Given this list of marker genes SSTR1, SOD3 (NCBI Gene Id 6649), GDPD3, PMEL, KIR2DL1, THBD, PCBP3, ZNF711 (zinc finger protein 711), MROH7, TESMIN, CKAP5, RNF186, CDK14, ATRNL1 (NCBI Gene Id 26033), GUCY1A1, CPT1A, SYNGR4, TAS2R14, BCL2L14, CPPED1, SMG7-AS1, KIR2DS4, ARHGEF3, POMZP3, MYOZ2, FOXD1, FCHSD2 (NCBI Gene Id 9873), CPS1, ART3, FLJ13224, KCNQ3, PWAR5, PRLR, HTR1D, PLG, RHBG, FST, HIF3A, RPL23AP53, TEC, KCNK15-AS1, SPO11, SERPINF1, KIR3DL1, PPFIA2, ADCY3, FAM204A, NEUROD6, HOXD1, VDR, FER1L4, GCNT3, DAB2, AMT, LINC00588, DNAJC12, RUBCNL, REN, PDZD2, AEN, SLC25A20, PDLIM7, TNFSF11, GRAMD1C, ZNF507, NKRF, UNC13B, VIPR2 (NCBI Gene Id 94613), ALDH4A1, MPDU1, LDB3, PCDHA2, MAMLD1, PLPP3, KCNJ14, IQSEC3, FAM131B, NPBWR2, XYLB, UCP1, GDF5, BEST2, KRT33B, SOBP, CNGB1, DRP2, PAFAH2, IL1RN, MYLK, PLD1, SLC39A2, TDO2, CD163, CHRM5 (NCBI Gene Id 1133), SIX6, CTTN, SLC2A9, CST5, ANXA2P3, SEMA5A, GPR88, MAGI2, IGFBP3, EXOSC1, SH3GL2, HABP2, KRT19P2, UBE2G2, PKD2L2, CLCN5, MSH4, TBX6, PRR3, ATP6V0A1, MZB1 (marginal zone B and B1 cell specific protein), HBQ1, TRPC6, IL1R2, FXYD3, DNAJC22, C5AR2, TMPRSS5, CUZD1, EGOT, RAMP3, REEP1, LY6G6C, EXTL2, VWF, B4GALT2, ZCWPW1, IL13RA1, GRIK3, BLNK, KSR1, RABEP2, SYT2, AADAC, NRG1, GYS2, KCNJ10, HLCS, RFPL3, FSCN3, DLGAP2, SPACA1, DGCR5, ITGB5, SATB2, GREM2, TUBA8, LEPR, MAGEA12, CLCC1, PEAK1, GABRE, PRR36, FAM182B, CACNG5, NRN1, SORCS3, L1TD1, BBOX1, FZD1, CNTN2, MOBP, MAP1LC3C, HOXC13, ANKRD7, CCL22, ADAMTS1, ELOCP28, AFF3, FDXR (NCBI Gene Id 2232), ANPEP, IBSP, NEFL, BDKRB1, NXPE4, PDLIM3, GPRASP3, EYA1 (NCBI Gene Id 2138), ADH1B, MGAT5, ELOVL2, JAK3, SLC6A3, FAM13A, DLL3 (NCBI Gene Id 10683), PARP3, PEX11A, ANKRD2, OR11A1, SCARA3, TUBBP5, ADAM5, SPAG6, CCN4, here is a description of the gene set: With increasing age, the ability of the immune system to protect against recurring infections or to control chronic infections erodes. The objective of the current study was to identify gene expression signatures in elderly CD4 T cell responses species: Homo sapiens Genes down-regulated in comparison of untreated memory CD4 T cells from young donors versus those from old donors. from publication Yu M, Li G, Lee WW, Yuan M, Cui D, Weyand CM, Goronzy JJ (PMID 22434910) Human Gene Set: GSE36476_YOUNG_VS_OLD_DONOR_MEMORY_CD4_TCELL_DN